The following is a description of a gene set: species: Homo sapiens Triggering of B cell receptors (BCR) induces a massive synthesis of NFATc1 in splenic B cells. By inactivating the Nfatc1 gene and re-expressing NFATc1 we show that NFATc1 levels are critical for the survival of splenic B cells upon BCR stimulation. NFATc1 ablation led to decreased BCR-induced Ca++ flux and proliferation of splenic B cells, increased apoptosis and suppressed germinal centre formation and immunoglobulin class switch by T cell-independent antigens. By controlling IL-10 synthesis in B cells, NFATc1 supported the proliferation and IL-2 synthesis of T cells in vitro and appeared to contribute to the mild clinical course of Experimental Autoimmune Encephalomyelitis in mice bearing NFATc1-/- B cells. These data indicate NFATc1 as a key factor controlling B cell function. Human Gene Set: GSE21063_CTRL_VS_ANTI_IGM_STIM_BCELL_NFATC1_KO_16H_DN Genes down-regulated in B lymphocytes with NFATC1 knockout: control versus stimulated by anti-IgM for 16h. from publication Bhattacharyya S, Deb J, Patra AK, Thuy Pham DA, Chen W, Vaeth M, Berberich-Siebelt F, Klein-Hessling S, Lamperti ED, Reifenberg K, Jellusova J, Schweizer A, Nitschke L, Leich E, Rosenwald A, Brunner C, Engelmann S, Bommhardt U, Avots A, Müller MR, Kondo E, Serfling E (PMID 21464221), and this is the list of marker genes: PGM2L1, IPO5, DNAJA2, ADAM17, PDE1A, TMEM218, ATG4A, PFDN5, GYPC, C2CD4C, ZNRF1, PDLIM2, CDR2, FBXL19, GPRIN3, PHAX, COBL, HNRNPDL, ABCB7, UFL1, FBXL18, METAP1, SHARPIN, GPN3, HBS1L (NCBI Gene Id 22991), HECW2, FRMPD3, GATAD2B, ZNF280D, NDUFAF6, MED23, LUC7L, KDM1A, SPRY3, PTBP1, TCF12, CAND1, TNFSF14, SGTB, MAST2, CNIH1, RCOR1, NHLRC3, PRELID1, SEC14L1, TSC22D3, WWP2, MAP3K2, MMP11, STK10, SENP6, CKAP4, NAP1L3, HSF1, ECD, NME2, NUP43, CERS6, SLC1A4, DGAT1, SELENOH (NCBI Gene Id 53396), SLC3A2, CLEC10A, CIBAR1, ZNF518B, DDRGK1, ADAT2, SGIP1, MAPK14, SNRPD2, FAM98B, RAB11FIP4, BCAT2, FAM110A, BMAL1 (basic helix-loop-helix ARNT like 1), PUS10, GALC, EIF3F, SYNE1, GKAP1, FHOD1, TFRC, TMPRSS13 (transmembrane serine protease 13), TNFAIP1, RILPL2, DNAAF10, IL22, INKA1, RCHY1, ZCCHC8, ITM2C, LSM3, GARS1, TRIM65, GPR132, RBBP5, SFR1, SLC49A4, CCDC63, PRR11, RPL14, PPP1R12B, NIPBL, TNF (tumor necrosis factor), EIF3A, PARD6G, RPL23A, RFC3, ZNF598, RCOR2, NBEAL1 (NCBI Gene Id 653928), EZH2, PPP1R14C, GGNBP2, FBXO5, SNORC, RAB2A, MYB, CENPP, SNHG6, SBNO1 (NCBI Gene Id 55241), YBX1, ZNF524, IL2RB, STARD5, MNS1, POLR2E, ATG16L2, RYR3, DAP, PROKR2, GTF2IRD1, KRAS, ROCK2, FLNB, MARVELD1, SNX10, UTP11, CTLA4, AVPI1, SMC6, CCDC93, WNT16, NIBAN1, ITGA3, C11orf54, COX11, SF3A1, C9orf85, CENPE, SEMA4C, NR4A2, PCBP2, IYD, MTF1, TJAP1, YAF2, DOCK10, RAD51B, TYW3, IRF2, MGME1, TGIF1, SIT1, CRISPLD2, NSG2, RELL1, SLC12A6, BHLHA15, TARS1 (NCBI Gene Id 94887), MED30, HS6ST1, ANGPTL4, NOL8, DOCK11, SRSF11, MBIP (NCBI Gene Id 51562), SPRING1, PRPF8, CCR6 (C-C motif chemokine receptor 6), NOL7, RPS21, PPP2R5D, SLF2, MRPL32, LAMA1, HAUS3, SNX5, SETDB2, SUV39H2, CHCHD10, IARS1, LRIG2 (leucine rich repeats and immunoglobulin like domains 2), CRAMP1, RIC8B, ZCCHC9, SAP30L, POLR1C, CBLL1